The following is a description of a gene set: Genes negatively differentially expressed in cell type: γδ T cell upon treatment with cytokine: IL-2 in mouse lymph nodes in vivo. Mouse Gene Set: CUI_T_CELL_GD_IL2_RESPONSE_DN studied in species Mus musculus Cytokines mediate cell-cell communication in the immune system and represent important therapeutic targets. A myriad of studies have highlighted their central role in immune function, yet we lack a global view of the cellular responses of each immune cell type to each cytokine. To address this gap, the authors created the Immune Dictionary, a compendium of single-cell transcriptomic profiles of more than 17 immune cell types in response to each of 86 cytokines (>1,400 cytokine-cell type combinations) in mouse lymph nodes in vivo. A cytokine-centric view of the dictionary revealed that most cytokines induce highly cell-type-specific responses. For example, the inflammatory cytokine interleukin-1β induces distinct gene programmes in almost every cell type. A cell-type-centric view of the dictionary identified more than 66 cytokine-driven cellular polarization states across immune cell types, including previously uncharacterized states such as an interleukin-18-induced polyfunctional natural killer cell state. from publication Cui A, Huang T, Li S, Ma A, Pérez JL, Sander C, Keskin DB, Wu CJ, Fraenkel E, Hacohen N (PMID 38057668), and this is the list of marker genes: Uba52, Ubb, H1f4, Clk1, Hcst, Cd96, Eci1, Hspa1a, Ccl5, Dap, Supt4a, Fau, Cxcr4, Selenop, Il18r1, Rmnd5a, Btg1, S1pr1, Fosb, Sdc1, Gmfg, Ech1, Eef1a1, Pdcd4, Pbxip1, Tsc22d3, Glud1, H1f2, Il7r, Crlf3, Entrep3, Itm2b, 9930111J21Rik2, Emb (NCBI Gene Id 218679), Crtc3, Ypel3, Pfdn5, Ets1, Fos, Paip2, Ddx5, Cited2, Smad7, Pglyrp1, Ramp3, Ccr6, Klrk1, Pnrc1, Tmem71, Hmgb2, Lztfl1, Dusp1, Klf6, Mpst, Cd7, Emp3, Jund, Eif3h, Arhgap15, Sptssa, Ing4, Acsbg1 (NCBI Gene Id 97577), Neat1, Cox7a2l, Rhob, Ppp1r15a, Zfp36l2, Kdm7a, Klhl24, H2az2, Btg2, Uqcrh, Fyb1, Tcf7, Acaa2, Crot, Bnip3l, Plin3, Neurl3, Cenpa, Ubc, Smpdl3a, Map1lc3b, Klf2, Cdkn1b, Junb, Tspo, Txk, Cd28, S100a10, St3gal6, Arl5c, Map4k4, H3f3b, Evl, Hspa1b, Nr4a1, Mxd4, Adgre5 (adhesion G protein-coupled receptor E5), Pik3ip1, Jun, Rgs2, Krit1, Txnip, Rgs10, Faah